Given this list of marker genes ANAPC11, RAD21, CDC20, ANAPC13 (NCBI Gene Id 25847), CDC27, ANAPC5, ANAPC1, PTTG1, ANAPC4, ESPL1, ANAPC7, CDC23, CDC26, ANAPC10, ANAPC2, CDC16, here is a description of the gene set: Human Gene Set: KEGG_MEDICUS_REFERENCE_COHESIN_DISSOCIATION_IN_ANAPHASE Cohesin dissociation in anaphase. Pathway ID: N01486. Pathway type: Reference. Pathway class: nt06512 Chromosome cohesion and segregation. species: Homo sapiens Pathway Definition from KEGG: ANAPC+CDC20 -| PTTG1 -| ESPL1 -| RAD21